The following is a description of a gene set: Any structural abnormality of the medulla of the kidney. Human Gene Set: HP_ABNORMAL_RENAL_MEDULLA_MORPHOLOGY studied in species Homo sapiens Abnormal renal medulla morphology, and this is the list of marker genes: NPHP4, DYNC2I2, DHX16, RPGRIP1L, IFT172, PDCD6IP, NPHP1 (nephrocystin 1), IQCB1, CLCN7, VPS33B, DCDC2, DYNC2H1 (NCBI Gene Id 79659), CEP120, TMEM216, GLIS2, PAX2, CRB2, TMEM67, DYNC2I1, DYNC2LI1, TTC21B, IFNG, KIAA0753, JAG1, UMOD, XPNPEP3, LONP1 (lon peptidase 1, mitochondrial), DZIP1L, NEK8, CEP83, AHI1, TRIP11, CEP164, BSND, IFT43, H4C3, NIPBL, NPHP3, MAPKBP1, IFT140, WDR19, INVS, FAN1, TSC2, PKHD1, TULP3, COQ7, MUC1, TMEM138, IFT80, SDCCAG8, CEP290, ZNF423, PBX1, AP2S1, ACTN4, CEP41, ZNF699, ANKS6, PDHA1, USP18, TRAF3IP1